The following is a description of a gene set: Human Gene Set: HP_WIDE_NASAL_BRIDGE Increased breadth of the nasal bridge (and with it, the nasal root). Wide nasal bridge studied in species Homo sapiens, and this is the list of marker genes: PPP1R21, TOE1, TRRAP, RALA, ADNP, RUNX2, BUD23, TMEM70, CDH11, VDR, TRPS1, NECTIN1, GTF2I, NALCN, RERE, PIK3R1, PEX26 (NCBI Gene Id 55670), TCOF1, SOX5, CHD2, ASXL1, SLC12A6, RSRC1, STAT3 (NCBI Gene Id 6774), GNPAT, GLUL, CHD3, CCNQ, TXNL4A, KPTN, PRKG2, SUFU, CCBE1 (NCBI Gene Id 147372), GPC3, FBXL4, TASP1, HNRNPK (NCBI Gene Id 3190), IFT52, TNPO2, WDR19, SKI, CILK1, IFT57, SOST, LTBP4, OPHN1, UFD1, FGFR1, WARS2, BMP2, KAT6B, KRAS, COL11A1, BRAF, RPS29, SPTBN1, SCN4A, RPS28, NOTCH2, RPS17, TRIM37, PRDM16, LUZP1, TMEM53, MPV17, FLNB, EP300, ESAM, COL27A1, SNX14, COG1, RPS10, VPS35L, EDEM3, ATAD3A, PIEZO2, RPL9, RELN, CTCF, NFASC, KCNH1, PAX1, PUM1, PGAP2, AP2M1, NAA10, ERCC1 (ERCC excision repair 1, endonuclease non-catalytic subunit), TPM2, RAD21, DPYSL5, FLI1, DNAJC30, SEC24C, DHX9, KDM4B, PRKCZ (NCBI Gene Id 5590), DPH5, TOR1A, RPS20, NUP88, PTCH1, PIGY, SHOX, PIGN, ATP6V0A2, TOGARAM1, NDUFB11, TNNT3, RPS7, SLC35A2, AMER1, AP4B1, PEX6, KIF14, QARS1, KCNAB2, GTF2IRD2, KCNJ2, RARB, PEX3, WLS, SNAP29, SKIC2, KDM6A, SMARCA4, POLR1C, FKBP6, KCNN3, RPL35A, SOX10, YARS1, PURA, ANKH, RPL26, FAT4, RPS26, PIGB, WDR35, RB1, RFC2, RPS24, CENPF, WAC, TBC1D20, JMJD1C, PBX1, NEU1, CLP1, SCO2, SOX18, NSD2, MYH3, SIN3A, ARX, ZBTB20, LRPPRC, MINPP1, RAC3, RPL27, PEX12, XRCC4, SCN1A, FBXL3, AP4S1, SLC6A1, MARS2, TMEM270, SPEN, EDNRB, ARMC9 (NCBI Gene Id 80210), GRIP1, BPTF, MAFB, PEX13, CKAP2L, ERCC6, SKIC3, B4GALT7, NCF1, TBCK, HNRNPR, ERCC5, PSMD12, KMT2A, HYOU1, MITF, SLC35C1, EED, DIS3L2, ALX3, SNAI2, FREM1, IRX5, PGAP3, EBF3, CDC42, CCNK, EIF4A2, TRPV6, ASXL3, BAZ1B, FGF3, RAB3GAP1, MMP23B, KIFBP, GTF2IRD1, EIF4H, MAPRE2, H4C5, ESCO2, RPL8, SVBP, FBXO31, KCNJ8, PARS2, SET, SLC1A4, PAX3, RAF1, FANCL, FOXC1, ZEB2, FUT8, GPRASP2 (NCBI Gene Id 114928), FBXO11, SMG9, PTCH2, STT3A, GNE, HS2ST1, ERI1, WNT5A, KIT, KCNJ5, SETD2, PQBP1, FGFRL1, UNC80, RPS19, AP3B1, RHOA, ACTG1, AGA, HEATR3, HIRA, WNT7A, RAB34, GPC6, ZMYM2, MEGF8, CLIP2, DLK1, FREM2, MGP, USP9X, EDN3, COMT, FLNA, PEX1, GJA1, TAPT1, PEX14, NEK1, INTS1, PIGG, UMPS, TUBGCP6, ROR2, PACS2, BRPF1, RAB18, HBA2, PKDCC, MYCN, TMEM94, SUPT16H, CHD8, PDE4D (NCBI Gene Id 654081), TNNI2, PLK4, LTBP3, EXOC2, IQSEC2, ALG3, CASK, TPR, CASZ1, SRCAP, PDPN, ALG2, GATA4, TBX6, SEC23A, KIF11, IFT122, RPL18, FRMPD4, PIGW, FOXL2, PRMT7, EFNB1, LMNA, CDK10, LIMK1, TWIST1, TAF4, MAPK1, KATNB1, NRAS, AHI1, TRMT1, HBA1, SYNGAP1, G6PC3, MEG3, GNPNAT1, BPNT2, ARSK, METTL27, SRD5A3, RBM10, SH3PXD2B, SETD5, PUF60, TMCO1, RPS27, PRKAR1A, POLR1D, TP63, SPECC1L, NSUN2, HIVEP2, AGO2, IGF1R, RPL15, CD96 (CD96 molecule), RPL31, ARVCF, KMT5B, DVL1, IFT140, PIGV, CCDC22, PEX16, COLEC11, HSPG2, RAPSN, PIK3C2A, AGO1, NUDT2, SMARCA2, MYT1L, COX7B, TWIST2, CDK13, OTUD6B, GABRD, ADA2, IDUA, CTNND2 (NCBI Gene Id 1501), UBE4B, DEAF1, KREMEN1, GPC4, UBAP2L, KDM1A, KMT2D, DCHS1, FRAS1, PRKDC, VPS37D, TRAPPC9, ALX4, GLI3, ATP6V1A, STRADA, ACOX1, RPS15A, KIAA0753, PIGT, PEX2, ERCC2, CSNK2A1, RYR1, DDX3X, ALX1, POLR1A (NCBI Gene Id 90784), ABCC9, MED13, COG5, TENT5A (terminal nucleotidyltransferase 5A), EDNRA (NCBI Gene Id 1909), FBN1, PEX10, DRG1, ADAMTSL1, LMNB1, BRF1, TBX1 (NCBI Gene Id 7413), RTTN, KIF7, NUP188, NOG, GAD1, RPL11 (NCBI Gene Id 6135), EXT1, AP4E1, WASHC5, TBC1D24, GABBR1, ELN, SMARCAL1, RLIM, PITX2, JARID2, PDGFRB, VPS33A, RPL35, TSR2, MAP3K7, PEX5, CHN1, IDS, ADAMTSL2, ADAMTS3, CAMSAP1, PAH, DHCR7, ACY1, OFD1, FZD2, ATRX, TUBGCP4 (tubulin gamma complex component 4), MECP2 (methyl-CpG binding protein 2), AUTS2, NELFA, APC2, SEMA5A, MKS1, RTL1 (retrotransposon Gag like 1), LZTR1, SON, PTPN11, PDHA1, STX1A, LETM1, MYRF (myelin regulatory factor), MAN1B1, RNU4-2, FLII, TFAP2A, SCNM1 (NCBI Gene Id 79005), MED12, KANSL1, SALL4, ZMIZ1, CREBBP, ACTB, SLC2A1, POLR1B, KNSTRN, CPLX1, PIGO, PIGL, BCAS3, ZSWIM6, C1GALT1C1, PIK3CD, DVL3, SOX6, RPL10, LARP7, RBL2, TBL2, GP1BB, SHANK3, SLC4A10, TRIO, RAI1, NXN, MAF, RMRP, HCCS, RAB3GAP2, PUS7, MID1, NEXMIF, MED13L, ARID1B, RREB1, ATP6V1B2, B4GALT1, PEX19, GATAD2B, PCNT, NDE1, LIG4, TCF4 (transcription factor 4), AHDC1, PEX11B, LTBP1, FILIP1, RPL5, STRA6, KCNMA1, ERF, CTBP1, FGD1, STAG2, HECTD4, SP7, GATA1, RIN2, CTSD, RFX7